Given this list of marker genes NDRG4, PTH, IGFBP3, ALAD, INA, PER3P1, ANO3, LILRP2, INSYN2A, KIF11, ATF7IP2, UGT2B4, HOOK1, POGLUT2, DPYSL5, WDR76, FREY1, MAGEB2, BEAN1, UBE2NL, SPRY4, PNP, KCNG2, FGL1, RGMB, KERA, LRRC77P, SRPK3, LRATD2, LINC00648 (NCBI Gene Id 100508007), DDX51, SERINC3, UNC5CL, RANBP10, CEP290, SMC1B, CENPO, PLEKHN1, PRIM2, CNNM2, TEX36, EPYC, MAN1A2, DENND2C, ZFP28 (ZFP28 zinc finger protein), PNLIPRP1, THEMIS, SETD4, MBLAC2, PLPBP, TTC38, SLAIN2, ZNF184, ZMYND12, TTTY12, AFF2, LINC01996, FAM89A, PNMA8B, GZF1, ZDHHC8BP, FIG4 (FIG4 phosphoinositide 5-phosphatase), PLD5, MAMDC4, BNC1, PPP1R3C, AOPEP, HHIPL1, COL11A1, TEX26, ATP1A1-AS1, ZNF555, SPA17, CCDC162P, CSF2, TSPAN6, CLLU1, ERI1, STXBP5-AS1, EPHA7, LINC00307, FAM238B, UTP25, ST7-AS1, AQP10, SERPINI1, ALOXE3, KIAA1328, MLX, PLIN2, TMEM170B, EPHA5, CLDN8, LINC00842, FCGR2B, TMEM232, SLC6A14, SHISAL2A, TENM1, FANCG, XKR6, PTGR2, LYNX1, LRRC4C, GANC, SLC41A3, ZNF577, CPNE7, TAL1, PLD4, MILR1, RETN, NMUR2, ZNF195, MCM4, MRFAP1, PSRC1, OTULINL, GNPDA2, LINC02877 (long intergenic non-protein coding RNA 2877), ANKMY2, TIGD4, ACTL6B, CCER1, PTPN13, BDNF-AS, ABCA9, SPRR2B, CFAP418, ENSG00000230725, MIR4453HG, CADM2, RBM46, SH3GLB1, PSMB7, LGSN, KIR3DL1, KANK2, ANKFN1, USP35, POLR1E, TPM2, PTHLH, FSIP2, RNF215, BDH2, BNIPL, ZNF536, RAB11FIP1, TTC23L, LINC01019, WDR77, PCDHB19P, OR2K2 (olfactory receptor family 2 subfamily K member 2), TAF7L, LMX1A, GRP, FAAP20, EFCAB6 (NCBI Gene Id 64800), FRMPD3, CCDC171, MORN3, KRBOX1, CD207, PEX6, ONECUT1, ERLEC1P1, IL1B, ZPLD1, CECR2, FABP6, KIF14, AMDHD1, ZNF512, HMCN1, GPLD1, OLFML2B, GPC5, DEUP1, DNAJC9-AS1, APOA1, NLRC3, PSMC3IP, AFP, RDH8, SCGB2A2, ZMYND10, RUNDC3A, ESRG, KCNE1, CXCL2, here is a description of the gene set: from publication Tassiulas I, Hu X, Ho H, Kashyap Y, Paik P, Hu Y, Lowell CA, Ivashkiv LB (PMID 15467722) Human Gene Set: GSE1740_MCSF_VS_MCSF_AND_IFNG_DAY2_DERIVED_MACROPHAGE_WITH_IFNA_STIM_DN Type I IFN-inducible gene expression in human blood monocytes primed with Type II IFN. Genes down-regulated in monocyte-derived macrophages: no priming, stimulated by interferon alpha versus primed by IFNG and then stimulated by interferon alpha. species: Homo sapiens